The following is a description of a gene set: studied in species Homo sapiens Catalysis of the reaction: a 3-hydroxy-fatty acyl-CoA = a enoyl-CoA + H2O. This reaction usually occurs in the reverse direction, leading to the reduction of the double bound of enoyl-CoA in position 2 or 3. Specific reactions catalyzed include: a 4-saturated-(3S)-3-hydroxyacyl-CoA = a (3E)-enoyl-CoA + H2O and a (3S)-3-hydroxyacyl-CoA = a (2E)-enoyl-CoA + H2O. Human Gene Set: GOMF_ENOYL_COA_HYDRATASE_ACTIVITY, and this is the list of marker genes: EHHADH, HACD1, HSD17B4, HACD3, ECHDC3, HTD2, CDYL, AUH, HADHB, HACD4, HACD2, ECHS1, HADHA